Given this list of marker genes SLC4A1, TARS1, AARS1 (alanyl-tRNA synthetase 1), ANK1, PIEZO1, CARS1, GTF2E2, RNF113A, SPTA1, EPB42, SPTB, KCNN4, GTF2H5, MPLKIP, ERCC2, ERCC3, here is a description of the gene set: studied in species Homo sapiens An elevation over the normal range of the average amount of hemoglobin per red blood cell (27 to 31 picograms/cell). Increased mean corpuscular hemoglobin concentration Human Gene Set: HP_INCREASED_MEAN_CORPUSCULAR_HEMOGLOBIN_CONCENTRATION